Given this list of marker genes THRB, THRA, SOX9 (SRY-box transcription factor 9), LTA4H, IGF1, CREB1, KLF2, KRAS, NFIB, here is a description of the gene set: studied in species Homo sapiens The process in which a relatively unspecialized cell acquires specialized features of a type I pneumocyte. A type I pneumocyte is a flattened cell with greatly attenuated cytoplasm and a paucity of organelles. Human Gene Set: GOBP_TYPE_I_PNEUMOCYTE_DIFFERENTIATION